Given this list of marker genes ACTA1, CLPB, PCCB, KCNJ2, SREBF1, SMO, CA2, EIF4A2, EP300, ACTN2, BAG5, PAM16, OXCT1, ARL13B, NKX2-6, ERBB4, KCNJ18, KRT16, GCLC, ENPP1, COQ7, MED11, SCN4A, IDUA, PLP1, INPPL1, IL12B, TRPV6, PURA, LIFR, PPP1R21, NDUFV2, PLCB3, DPM1, SLC26A4, MYLK, PI4KA, NFS1, GALK1 (galactokinase 1), OSTM1, HACE1, GBA1, PON2, HIBCH, NDUFB11, ACTC1, UBQLN2, MPLKIP, PLEKHG5, IKZF1, KLRC4, KCNE2, BCHE, MMUT, NODAL, UNC45B, ETFA, MT-CYB, ARSB, NUP88, SMPD4, CAPNS1, ACTA2, SFTPB, IFT52, VAPB, DOK7, NOTCH2NLC, SPOP, PSAT1, KCNE3, SMPD1, PRKG1, WDR45B, CUL7, TECPR2, FDX2, CAV1 (NCBI Gene Id 857), IL17F, VHL (NCBI Gene Id 8056), CHRNA1, P4HTM, B3GALT6, GUSB, COG7, PRPH, CRLS1, CFAP300, RFT1, PRUNE1, CTCF, NAXE, CFAP298, BRAT1, SLC7A7, SLC26A9, PPARGC1A, PLCH1, SLC22A5, FARSB, DRC1, SEPTIN9, TNNC2, ABCG8, PRRX1, TBX1, CACNA1S, AAAS, JAG2, REEP1 (NCBI Gene Id 65055), SFTPA2, GFPT1, PRIM1, PMP22, CLXN, NPHS1, HMBS, ATRX, CACNA1A, KATNB1, SCYL2, SURF1, CLCF1, ARL6, UBA1, PWAR1, PLN, TRAIP, CCDC65, ERCC2, TSEN34, DNAI2, TET2, MEGF10, PIGT, STXBP1, KCNJ6, TOR1A, CANT1, NGLY1, SCN4B (sodium voltage-gated channel beta subunit 4), SARS2, RIPPLY2, BBS2, OFD1, MT-TN, TBX5, SYNE2, CC2D2A, ACOX1, VAC14, MT-CO3, SPEF2, HACD1, TCTN3, CNTN1, KCNJ10, MT-TE, DEPDC5, MT-ATP6, GM2A, NDE1, GABBR2, SLC2A10, PAX7 (paired box 7), JPH2, BTK, ABCD4, SLC25A4, MRPL39, DLL3, ZIC2, IFT140, NME5, HNRNPA1, COG1, SH3TC2, FAM13A, TLL1, HBB, LMOD3, NFIX, DZIP1L, ORC4, NKX2-5, RHAG, DLL1, UBE3B, SLC12A6, TNFSF11, PON3, GAS1, LTBP4, THSD4, SLC30A9, GNE, LDLRAP1, MIA3, CEP120, POU6F2, SRP54, PLCB4, LZTFL1, TWNK, CARD10, RALGAPA1, SERPINH1, BDNF, MUC5B, WDR19, STING1, TEFM, SLC26A2, SNX10 (NCBI Gene Id 29887), GABRA3, WDPCP, MMAB, BCOR, PTGER2, THBD, DAO, SLC39A7, LBR, SLC27A4, JUP, VCL, SNRPN, PYGM, CHRNB1, SMN1, TERC, SKI, ALDH1A2, SIK3, USP18, EOMES, DCTN1 (NCBI Gene Id 82109), PRRT2, LPIN2, TBR1, COX8A, ARL2BP, POLG2, MT-CO2, DPP9, NDUFS2, SLC25A21, NDUFV1, FOXP2, PAX8, TRIP4 (NCBI Gene Id 9325), SLC25A12 (solute carrier family 25 member 12), TRIM2, TNFSF12, MEFV, SP110, SDCCAG8, TGIF1, TBK1, GAA, GOSR2, FOXG1, GJA5, MS4A1, FZR1 (NCBI Gene Id 8855), ECHS1, MOGS, PRKAR1A, PLA2G6, IGF2, SEMA3E, FKRP, UFD1, POLR1B, GRM7, TBCK, PITX2, MORC2, CCNO, NUP214, ATP13A3, GGPS1, SLC25A24, LRPPRC, GLA, COL1A1, VEZF1, GIPC1, ACP5, INVS, ABCB4, FAT4, COPA, MUC7, NTNG1, DLL4, NRAS, PSEN1, ATXN2, SPTLC2, RFC1, CD79B, SUCLG1, ATP1A3, FIG4, TGFB2, PIGA, SLC12A3, AIFM1, HAND2, FKBP10, KARS1, NPAP1, ZMYND10, LONP1, CCNF (cyclin F), RSPH9, CTLA4, POT1, VMA21, AFF3, ATL1, BBS9, PUS1, HERC2, KBTBD13, SLC34A2, FHL1, ADAMTS13, JAK2, IL10, TBX4, SCNN1B, TRPM4, ASNS, INPP5E, CR2, FGF13, NDUFB3, KCNQ2, PPCS (NCBI Gene Id 79717), MKKS, PRDM13, TMEM138, UNC13A, CDC45, NDUFS7, SCAPER, ABCA12, BRWD1, MAGEL2, CRIPTO, OCA2, LIAS, CREBBP, PRPS1, PUF60, TGFB3, SLC2A1, DLK1, TMEM43, COL6A2, KIF21A, COL12A1, RFX7, KIT, FGF8, DNAAF11, KLHL7, LAMB3 (NCBI Gene Id 3914), PTF1A, EDA, PEX16, IFT74, TNNT1, RPL3L, CLCN7, ZMPSTE24, CASK (NCBI Gene Id 8573), POLR1C, KCNN4, NUBPL, NUTM2B-AS1, PEX7, SNAP25, MID1, GATA2, PRKAG2, DNAH11, CSRP3, ZBTB16, BUB3, CSF2RA (colony stimulating factor 2 receptor subunit alpha), EMD, CRH, USP7, IL13 (interleukin 13), KCNJ3, SYNE1, CYB5A, PON1, SH2B3, PIK3CA, ENG, DNAL1, POLR1D (RNA polymerase I and III subunit D), SCN5A, PGM1, TBCD (NCBI Gene Id 6904), DMD, HLA-DQB1, MYL2, MADD, CBS, UBE2A, FBXO28, LYN, KRT6B, MFN2, TPM1, HMGCR, LTBP3, LAMA3 (NCBI Gene Id 3909), BOLA3, HLA-B, DHX16, TARDBP, HDAC4, GSTM3 (glutathione S-transferase mu 3), ASXL1, AEBP1, SERPINA1, HSD3B2, XYLT1, C4B, PBX1 (NCBI Gene Id 5087), ARVCF, TINF2, CRPPA, IFT81, DDC, CYBC1, MIR140, STX1A, TCF4, LACC1, BICD2, HLA-DPB1, RUNX2, ETFB, ERI1, SH3BP2, STT3B, AGTPBP1, ERBB3, PTRH2, HMGA2, SLC11A1, ASCL1, LIN28B, MYH7, UFM1, SEC31A, SELENON, LGI4, JMJD1C, RIPK1, TUBB4A, PEX1, VPS51, FAM20C, VRK1 (VRK serine/threonine kinase 1), SLC18A3, DNAAF6, ERF, CYBB, COL3A1, MT-ND4, CARD11 (NCBI Gene Id 84433), SNRPB, MYOT, PTPN22, UQCRC2, COL13A1, STAT1 (NCBI Gene Id 6772), KRAS, MTMR14, TRIM32, HCCS, XPNPEP2, LAMP2, PIGN, LMO1, NDUFA9, TRAF3IP2, MT-ND2, MYH11, CD40LG, DNAAF5, TIMMDC1, MCIDAS, REST, SMARCE1, PCK1, ORC1, PLCG2, PLOD1, HNRNPA2B1 (NCBI Gene Id 3181), SCN9A, RTEL1, CHRNA4, SLC35A1, B2M, PEX13, TRRAP, LBX1, LMOD2, KAT6A, TMEM107, TRIP13, STIM1, SOD1, FIP1L1 (factor interacting with PAPOLA and CPSF1), TRAF7, SLC25A20, FLG, ADAM22, DYNC2I2, MT-ATP8, ITCH, GFRA1, RMRP, PLEC, SLC1A3, ELP1, SRPX2, AGO2, MT-TK (NCBI Gene Id 4566), SCLT1, KRT17, ACADM (acyl-CoA dehydrogenase medium chain), RBM20, NDUFA8, COL11A1, RNASEH2A, CARS1, ATP5F1E, MPV17, SIX3, GP9, HMGCL, CACNA1C, TK2 (thymidine kinase 2), DNAJB6, MYO1H, RPA1, NDUFAF3, SLC6A9, TNFRSF13C, NBN, DNAH5, FOXE3, LIPT1, DPYD, ALDH7A1, ALK, HRAS (HRas proto-oncogene, GTPase), VPS33A, ERCC3, SLC31A1, GATA5, BUB1, CASP8, FAS, CDKL5, RREB1 (ras responsive element binding protein 1), CD19, CD55, CDC6, COX4I2, CFAP74, PRNP, BSCL2, GRHL2, MFAP5, MAMLD1, B9D2 (B9 domain containing 2), ABCB11, HPS1, KCNE1, ODAD2, DLEC1, COL6A1, NEXN, HCK, CLEC7A, IGLL1, LAMB2, DCX, CA5A, SPP1, ABCG5, KCNA5, PTCD3, CDT1, EIF2AK4, THPO, PML, GPC3, BRAF, NEK10, CHST3, BMPER, SCARF2 (scavenger receptor class F member 2), TTC8, IRF5 (interferon regulatory factor 5), RNASEH1, NOD2, PEX11B, DOCK8, TOGARAM1, RPS26, SF3B4, PCCA, NFKB1, TUFM, PLAGL1, DNM2, GYG1, SMARCB1, AP3D1, SGCG, HPS4, GABRA1, GDNF, WFS1, GNPTAB, RHD, KNSTRN, TTC19 (NCBI Gene Id 54902), LAMA4, COX11, FOXE1 (forkhead box E1), KIAA0319L, CFAP410, ACY1, GGT1, VARS2, AARS1, FKTN, GMPPA, FAM111B, SCO1, PHYH (phytanoyl-CoA 2-hydroxylase), RIC1, SEPSECS, SMAD9, CDON, CHRND, PIEZO1, RSPH4A, CPT2, TRAK1, SIK1, CFTR, ATP5F1B, BAG3, NRXN1, GNA11, PYROXD1 (pyridine nucleotide-disulphide oxidoreductase domain 1), RPGRIP1L, SLC25A46, EXOSC3, NECTIN1, SFTPA1, SCN1B, NOS1, LRP5, TALDO1, ARX, TICAM1, RNH1, CDC42BPB, ALMS1, DTYMK, HIRA, MKS1, NACC1, TPM3, CACNA1H, ZNF423, HLA-DQA1, NPPA, NKX2-1, CFL2, HADHA, GRIN1, POMT1, ALG1, UNC93B1, CYP27A1, MPEG1, ODAD3, ALG12, CRLF1, SBDS, F8, PEX6, ODAD4, KLHL24, IFIH1, TMPO, NAA10, FREM2, SLC25A1, PRKCSH (NCBI Gene Id 5589), HLA-DPA1, TGFBR2, PANK2, ADPRS, PDCD1, PSAP, IL17RA, SPEG (striated muscle enriched protein kinase), IFNGR1, TP63, ALG9, GNAQ, PAX2, IRF6, IBA57, GCSH, KRT18, PRDM16, FOXP3, PGM3, TSEN54, CDSN, ALG14, JAK1, PWRN1, PROS1, DDRGK1, UQCRFS1, DPAGT1, CCDC28B, CPLANE1, MDFIC, NR1H4, ARV1 (NCBI Gene Id 64801), CEACAM3, GTF2H5, PNKD, IL6, ADAMTSL2, SCN3B, SETD2, STAT5B, ATXN1, DBH, P4HA2, FBXL4, IFT56, IFT172, BBS7, TSPYL1, KCNA1, TNPO3, IGHG2, TFAM, AMT, ATP5F1A, MGAT2, RNU4-2, SCARB2, GLI2, SNORD115-1, ANKRD1, ANG, MYMK, LARGE1, SCO2, DOCK11, IL12A, NDUFAF1, IRF4, STAT3, NFASC, COL4A6, LOX, SLC19A3, DNASE1L3, IL12A-AS1, ZSWIM6, EDNRA, ADSS1 (NCBI Gene Id 122622), UBAP2L, CAP2, CISD2, TCTN2, BAP1, SFTPC, SPINK5, TERT, MTHFR, RET, UNC45A, ATAD1, ATP5MK, STAT2, NSUN2, TMEM126B, RMND1, HFE, MYBPC1, BUB1B, IL1RN, KIF20A, HNMT, CPS1, GARS1, TOPORS, BRCA2, TTC21B, WAS, BBS5 (NCBI Gene Id 428), CHRNG, MED12, FOXF1, ATPAF2, SCNN1G, LYRM4, PIEZO2, RNF13, BIN1, POMT2, TTC12, BBS1, TRIP11, HEY2, GMPPB, FRG1, MT-ND5, TNFRSF13B (TNF receptor superfamily member 13B), KIF7, IDS, NFU1, POMK (NCBI Gene Id 84197), GRIK2, AFF4, GLB1, ATP1A2 (NCBI Gene Id 93186), ACVR1, B9D1, ACAT1, DYNC2H1, FBN1, ADCY6, SEC24C, PEX10, CDKN1C, NCF4, COQ2, TUBA1A, MKRN3, DNAJB13, PEX12, WDR35, RNF6, DYNC2LI1, COL1A2, HLA-DRB1, TGFBR1, MYOD1, MT-TL2, CCDC103, HSPG2, NPHP1, DUX4L1, HADHB, NUP155, PRDX1, ACAN, RSPH1, SLC4A1, NEMF, MPC1, NDUFA6, LAMA2, SAT1, CCL11, COQ9, CCR6, GPX4, GTF2E2, OCRL, FHL2, SLC25A3 (solute carrier family 25 member 3), CAMK2B, ACADSB, TOR1AIP1, SCNN1A, SUFU, FCSK, MTR, DEF6, BLNK (B cell linker), GDAP1, NDUFA11, MYL3, SYT1, MUSK (NCBI Gene Id 4593), DOLK, CCDC40 (coiled-coil domain 40 molecular ruler complex subunit), EPHB4, IL17RC, UBAC2, WT1, CIZ1 (NCBI Gene Id 25792), AKT1, DNA2, WWOX, CNOT1 (CCR4-NOT transcription complex subunit 1), NCF1, ODC1, MYCN, GATA4 (NCBI Gene Id 2626), SCN2A, MARS1, LRBA, SMCHD1, AMER1, VCP (valosin containing protein), SLC9A3, ADGRG6, BBIP1 (BBSome interacting protein 1), DISP1, DSC2 (desmocollin 2), RAP1GDS1, CHCHD10, MED25, IFT80, ZIC3, NCF2 (NCBI Gene Id 4688), PEX14, PIK3R1, JAG1, ELN, EXOSC8, APC, DMPK, FOXJ1, OAS1, HYLS1, TP73, COX5A, HYDIN, COL6A3, DNAAF4, SHH, ERAP1, FOXRED1, NDUFS8, SLC52A3, STK36, CSPP1, LTBP1, RPGR, SSR4, PKHD1, POGLUT1, KCNJ11, ERGIC1, ITGA7, SLC6A14, MYH3, ABCC9, FOCAD, MCCC1, KIAA0586, CNTNAP2, FLNC, FGFR1, SEC63, DKC1, GNB1, SDHA, SLC37A4, ATP11A, GAS8, FARS2, GALC, EXOSC9, ABCC6, CEP41, TBX20, CLCA4, EOGT, SLC25A15, COX6B1, GNAI3, RNF168, CD79A, POR, PROC, NDUFS3, MT-TH, TLR4, PEX19, SGCD, PPOX, COL2A1, GABRB3, DNAAF3, PIK3CD, INPP5K, GNB2, SLC39A8, DDX41, MESP2, F12, TMEM218, RSPH3 (radial spoke head 3), MSX1, DYNC2I1, STAG2, HEXA, DNAI1, LYRM7, IL23R, SMC1A, JRK, SLC52A2, KCNK3, CHRNB2, CCN2, MYO9A (myosin IXA), MYT1L (myelin transcription factor 1 like), IFNG, MRPS14 (NCBI Gene Id 64961), TAMM41, GSC, KLHL40, AGK, CFAP52, OPA1, TNNI3, MT-ND3, ACVRL1, DSP, ENSG00000288330, SLC6A5, MT-CO1, CBY1, GATA6, RNU4ATAC, TMEM237 (transmembrane protein 237), PFN1, DES, MLX, MTM1, SBF2, STN1, NDUFAF8, SNUPN, RAF1, NDUFAF4, CRYAB, FLNB, NEK9, NDUFS6, IFT27, TCF3, SLC41A1, COL11A2, ARL3, PCSK9, STX16, CNTNAP1, SMAD4, USP9X, SCGB3A2, RHCE, RANBP2, RELB, DPM2, FARSA, RARS2, RBPJ, MAP2K1, MYBPC3, DNAH9, NHLRC2, GPC4, ASL, NR4A2, CSGALNACT1, FOXH1, FGFR3, ATXN8OS, COMT, RNF113A, TRIM28, FLNA, CSF2RB, TREM2, TRPV4, GLYCTK, NDUFS1, TMEM70, PEX2, CEP57, MYD88, RRM2B, HABP2, SDHD, TPM2, F2, ADA, SPI1, F13A1, TLK2, MMAA, MICOS13 (NCBI Gene Id 125988), NDN, AK9, CASR, CFAP221, NDUFA10, TGFB1, IRF2BP2, MT-TF, PEX5, CHAT, PTCH1, IL2RG, CARMIL2, NEK1, TCTN1, GMNN, MRPL3, ATP6V1B2, RELN (NCBI Gene Id 5649), ZFPM2, PIBF1, MT-TL1, COQ4, HES7, FOXI1, NALCN, C4A, NUP188, GLE1, PDGFB, POLR1A, MT-TV, KCNQ1 (NCBI Gene Id 3784), AHDC1, SYT2, ALAD, DUX4, TSC1, TMEM231, PNPLA2, SPG11, TRAF3, TNNC1, AGGF1, H19, TNNT2, CLCN6 (chloride voltage-gated channel 6), COL4A5, DNM1L, EFTUD2, MINPP1, GPHN, PRTN3, NF2, ACADVL, ADAMTS3, MAP3K7, MT-ND6, CD81, PARN, NDUFB9, EDN3, PLOD2 (procollagen-lysine,2-oxoglutarate 5-dioxygenase 2), ALPL, HDAC9, LAT, ZNF699, NFKB2, MECP2, CYBA, LRRC8A, MLYCD, NPM1, AGR2, LMX1B (LIM homeobox transcription factor 1 beta), IL6ST, PLAA, PIGY, TFG, MATR3, RTL1, RAC2, KYNU (NCBI Gene Id 8942), ISCU, TAFAZZIN, ETFDH, CHRNE, GABRG2, FAM149B1, COX14, EPOR, KATNIP, ACE, LRRC56, CLCNKB, GET3, SERPING1, CYB5R3, COL25A1, PEX3, ANXA11, SLC25A26, NPC2, ATP5F1D, RPS28, SHPK, KRT6A, MT-TW, LAMC2, CFAP45, PDE6D, LRP12 (NCBI Gene Id 80002), PEX26, ALAS2, TAF15, PEPD, BMPR2, DYM, BBS4, CACNA1D, EGR2, MCM4, SERPINC1, RARA, CEP19, THSD1, CTSD, NSF, WDR11, AGTR1, ADGRG1, TCIRG1, SMAD2, PDSS1, FLAD1, COA8, TRMT10C (tRNA methyltransferase 10C, mitochondrial RNase P subunit), SMARCAL1, TMEM67, TLR3, CHD7, CHRNA2, NDUFAF6, MTOR, SNORD116-1, GLS, HSPD1, ESAM, ATL3, TOE1, ARSL, RYR1, MYF6, TBL1XR1, GLI3, REN, APOB, ASAH1, PSEN2, MMACHC, FBP1, SLC5A7, TTN, STAC3, SUCLA2, DIS3L2, MIF, OTX2, AHI1, SETBP1, ARMC9, CCR1, PLAG1, NDUFA2, STAT6, ADNP, HNRNPK, STAT4, MTTP, CFAP418, DSG2, KIF22, TSFM, MPL, DYSF, MT-TT, CEP290, OPTN, SCN8A, MAPT, WIPF1, KIF5A, NUMA1, NDUFAF5, ZNF148, FOXP1, NDUFB8, DDR2, DNAJC21, BTD, CTSK, DNAAF2, HLA-G, PKP2, ARHGAP31, POLG, LMNA, GLUL, MT-TS2, KCNQ3, ACADS, MCCC2, MEG3, MYL1, NDUFAF2, COX7B, CCDC39, BBS10, MAP3K20, DOCK6, SMAD3, XYLT2, RAPSN, TCOF1, NDUFS4, IDH1, MYL4, LARS2, SOX9, TSEN2, BBS12, HOXA1 (NCBI Gene Id 3198), ALOX5, BLM, ORAI1, TBC1D24, ORC6, CEP104 (centrosomal protein 104), MT-TQ, TPI1, TRAPPC11, COA6, AGT (angiotensinogen), IGHM (NCBI Gene Id 3507), HLCS, ZC4H2, COLQ, SMC5, PSMB9, PDHA1, GLRA1, NABP1, FBLN5, MB, SQSTM1, ITGA3, GLT8D1, TRMU, AHCY, IGKC (NCBI Gene Id 3514), GRB10, GP1BA, SMPX, NDUFB10, MPZ, TXNRD2, EFEMP2, PABPN1, VAMP1, MYZAP, CEACAM6, RILPL1, MYPN, SATB2, KCNT1 (NCBI Gene Id 57582), ICOS, PIP5K1C, IRAK1, EDN1, IKBKG, PLPBP, CCDC174, IPO8, ELOVL4, SLC18A2, CABP4, ODAD1, DAW1, GNAS, PMM2, D2HGDH, IGHMBP2, LIPT2, FCGR2A, TNF, KDM6A, TMEM216, NEB, SCN2B, DNAH1, PHOX2B, CCBE1, TXNDC15, GAS2L2, DNAJB4, FCGR3A, GATAD1, KCNJ5, MYOZ2, NAGS, HMOX1, CPOX (NCBI Gene Id 201541), KAT6B, ASCC1, NOTCH1, ABCA3, MTFMT, TSC2 (NCBI Gene Id 7249), GALNS, DNAAF1, HTRA2, KIAA0753, CITED2, NME8, TRMT5, BANF1, FBXO11, GP1BB, WAC, NEFH, LDLR, TCAP, G6PC3, SPAG1, TBX21, MAT2A, LRP4, DDX3X (DEAD-box helicase 3 X-linked), DCTN4, BCL11B, LFNG, NLRP3, FUS, NF1, COX6A2, YARS2, DAG1, STIL, DST, ATP8B1, KLHL41, PLXND1, TARS1, CHD6, GDF2, TAF1A, RBM10 (NCBI Gene Id 8241), DNMT3B, KMT2D, HPDL (4-hydroxyphenylpyruvate dioxygenase like), APOA1, SLC29A3, HYMAI, LIG4, CHMP2B, MT-ND1, NDUFA1, LDB3, TSEN15, GTPBP3, FGFR2, RNF125, MGP, MGME1, MYH6, AGRN, SON, STRA6, BTNL2, SPTLC1, here is a description of the gene set: Abnormal respiratory system physiology species: Homo sapiens Abnormal function of the respiratory system. Human Gene Set: HP_ABNORMAL_RESPIRATORY_SYSTEM_PHYSIOLOGY